The following is a description of a gene set: Chronic lung disease studied in species Homo sapiens Human Gene Set: HP_CHRONIC_LUNG_DISEASE According to the definitions of the American and British Thoracic Societies, including pulmonary functional tests, X-rays, and CT scans for items such as fibrosis, bronchiectasis, bullae, emphysema, nodular or lymphomatous abnormalities., and this is the list of marker genes: STIL, RIPK1, KIAA0586, ABCA3, FOXE1, BLM, THSD1, TGFB1, CRIPTO, ZNF699, CFTR, ZIC2, HABP2, SHH, PLCH1, SERPINH1, LRRC56, CTCF, LAT, CDON, PEPD, PTCH1, AFF4, PIGY, FGFR1, FGF8, GAS1, PRIM1, ITCH, LRBA, STAG2, DISP1, MINPP1, NODAL, FCGR2A, CSPP1, DLL1, SIX3, GLI2, SMC1A, FOXH1, SFTPB, TGIF1